The following is a description of a gene set: species: Mus musculus A conserved hetero-pentameric membrane-associated complex involved in retrograde transport from endosomes to the Golgi apparatus. The budding yeast retromer comprises Vps35p, Vps29p, Vps26p, Vps5p, and Vps17p. The mammalian complex shows slight variation in composition compared to yeast, and comprises SNX1 or SNX2, SNX5 or SNX6, VPS26A or VPS26B, VPS29, and VPS35. Mouse Gene Set: GOCC_RETROMER_COMPLEX, and this is the list of marker genes: Magel2, Dctn1, Entr1, Vps35, Snx27, Ankfy1, Trim27, Vps29, Snx2, Snx12, Dennd5a, Tbc1d5, Snx6, Snx8, Vps26b, Dennd4c, Snx1, Rab7, Snx5, Snx3, Vps26a (VPS26 retromer complex component A)